The following is a description of a gene set: Human Gene Set: GOBP_ENDOPLASMIC_RETICULUM_PLASMA_MEMBRANE_TETHERING species: Homo sapiens The attachment of an endoplasmic reticulum membrane to the plasma membrane via molecular tethers., and this is the list of marker genes: VAPB, ESYT2, ESYT1, GRAMD2A, ESYT3, VAPA